The following is a description of a gene set: species: Homo sapiens part of: Drug ADME Reactome Pathway: Aspirin ADME In water aspirin (acetylsalicylic acid, ASA) dissolves, dissociating into the acetylsalicylate ion (ASA-). ASA- is an anti-clotting agent and nonsteroidal anti-inflammatory drug (NSAID); the therapeutic effects are mediated through its interaction with PTGS enzymes. On a molar basis ASA- (a) is more potent as an analgesic/anti-inflammatory agent, (b) has greater gastric ulcerogenic activity, and (c) is much more effective as an inhibitor of prostaglandin biosynthesis and platelet aggregation than salicylate (ST).<br>Acetylsalicylic acid is only slightly soluble in conditions being found in the stomach mucosa, mostly because of unavailability of sufficient amount of solvent. The absorption, as well as the absorbing area, increases in the small intestine. Further increased absorption is achieved by dissolving tablets before ingestion or usage of ASA salts. Practically 100% of therapeutic aspirin doses are taken up, mostly by intestinal mucosal cells (Artursson & Karlsson, 1991; Yee 1997).<br>Only a few percent of ASA- remain unchanged, the rest is hydrolyzed to salicylate (ST). The major route of ST catabolism is conjugation with glycine to form salicyluric acid. This accounts for 20–65% of the products. Conjugation to glucuronides (ester and ether) removes up to 42% of ST. Finally, a minor part also gets hydroxylated by cytochromes., and this is the list of marker genes: UGT2A2, UGT3A1, UGT1A1, UGT2B7, BSG, ABCC3, CYP2C8, SLC16A1, UGT2B11, UGT2B15, UGT1A3, CYP2E1, ACSM4, UGT2A1, UGT1A7, UGT1A6, SLCO2B1 (solute carrier organic anion transporter family member 2B1), CES2, GLYATL3, CYP3A4, UGT3A2, ACSM2B, CYP2D6, ABCC2, UGT1A5, UGT2B4, UGT1A9, UGT1A4, BCHE, CYP2C9, ACSM2A, CES1, CYP2C19, UGT2B17 (UDP glucuronosyltransferase family 2 member B17), UGT2B28, GLYATL1, UGT2A3, UGT2B10, GLYATL2, SLC22A7, GLYAT, UGT1A8, ALB, ACSM5